The following is a description of a gene set: studied in species Mus musculus Mouse Gene Set: chrXA3, and this is the list of marker genes: Btbd35f29, Btbd35f8, Rhox11-ps1, Rhox3d-ps, Rhox3c, Gm14819, Gm2309, Gm6024, Mcts1, Rhox4a, Tmem255a, Ube2a, Rhox10, Snora69, Rhox3e, Gm15432, Ct47, Gm10486, Gm10488, Sowahd, Gm14564, Spin2h, Gm2165, Gm15279, Rhox6, Gm3657 (NCBI Gene Id 100042087), Gm15273, Spin2g (spindlin family, member 2G), Spin2j, Zfp36l1-ps, Rhox3h, Gm24147, Steep1, Rhox4g, Gm6023 (predicted gene 6023), Rhox13, Btbd35f5, Gm14550, Spin2-ps6, Pgrmc1, Gm16423, Gm14632, Rhox11, Atp1b4 (ATPase Na+/K+ transporting, beta 4 polypeptide), Spin2e, Rhox4b, Gm15008, Gm26099, Rhox2g, Gm14541, Rhox4e, Gm7437, 6030498E09Rik, Gm7421, Gm10096 (predicted gene 10096), Btbd35f2, Btg1b, Gm40, Rhox2f, Rhox2e, Rhox2b, Btbd35f6, Rhox2c, Gm10147, Btbd35f22, Rhox3a, Gm2223, Gm7598, Rhox4d, Gm22364, Gm14552, Ndufa1, Rhox5, Cul4b, Gm10487, Akap17b, Btbd35f9, Rhox4a2, Cypt15-ps (NCBI Gene Id 78631), Rhox2a, Gm4836, Spin2-ps8, Zcchc12, Rhox4f, Rhox3f, Gm7438, Nkap, Gm7408, Mir3110, Akap14, Rhox7-ps1, Gm14567, Gm3681, Btbd35f13, Btbd35f14, Rhox9, Btbd35f1, Spin2f, Gm3669, Gm2288, Rhox3g (reproductive homeobox 3G), Gm7415, Gm14527, Gm4764, Nkrf, Gm7023, Spin2-ps7, Rhox2h, Btbd35f21, Lamp2, Btbd35f15, Gm4853, Btbd35f26, Dock11, Gm9, E330016L19Rik, Gm14569, Rnf113a1, Ap3s1-ps1, Gm15281, Gm14570, Gm14551, Gm2231, Gm23613, Lonrf3, Cypt14-ps, Zbtb33, Rhox3a2, Btg1c, Btbd35f25, Gm14554, Gm7391, Rhox7-ps2, Rpl7-ps9, Rhox1, Btbd35f12, Btbd35f19, Rhox12, Dppa3-ps, Rhox7a, Spin2-ps10, Rhox2-ps, Gm2318, Septin6, Rhox4c, Rhox2d, Il13ra1, Rhox3b-ps, Rhox11-ps3 (NCBI Gene Id 104053954), C1galt1c1, Rpl39, Slc25a5, Gm2066, Rhox7b, Slc25a43, Gm2200, Gm14974, Gm2182 (predicted gene 2182), Gm26437, Gm7398, Gm14571, Rhox11-ps2, Gm25624, Rhox8, Upf3b